The following is a description of a gene set: Narrow nose Human Gene Set: HP_NARROW_NOSE Interalar distance more than 2 SD below the mean for age, or alternatively, an apparently decreased width of the nasal base and alae. species: Homo sapiens, and this is the list of marker genes: TRRAP, RNU4ATAC, POLE, RNU4-2, POLR3A, CARS1, PDGFRB, FBN1, ERCC8, FGFR2, SCARF2, DDR2, HYOU1, GJA1, SATB2, SMC1A (structural maintenance of chromosomes 1A), ACP5, TWIST1, TP63, EYA1, PYCR1, MED12, COL5A1, LMNA, CCNQ, ABL1, TGDS, SLC26A2, ERCC6